The following is a description of a gene set: Any process that modulates the frequency, rate or extent of defense response to fungus. Human Gene Set: GOBP_REGULATION_OF_DEFENSE_RESPONSE_TO_FUNGUS studied in species Homo sapiens, and this is the list of marker genes: POMC, TRIM62, SPI1, FAM3A, PLA2G5, ARG1, USP15